The following is a description of a gene set: studied in species Mus musculus Mouse Gene Set: GOMF_NUCLEAR_THYROID_HORMONE_RECEPTOR_BINDING Binding to a nuclear thyroid hormone receptor., and this is the list of marker genes: Rxra, Med4, Med30, Gtf2h1, Taf11, Nr0b2, Trip12, Med1, Taf7, Med17, Tacc1, Med12, Med16, Prmt2, Arid5a, Rxrb, Nsd1, Gtf2b, Thrap3, Med13, Hr, Fus, Ncoa2, Brd8, Med24, Ncoa6 (nuclear receptor coactivator 6), Psmc3ip, Nup62, Ncor1